The following is a description of a gene set: High-throughput gene expression profiling has become an important tool for investigating transcriptional activity in a variety of biological samples. To date, the vast majority of these experiments have focused on specific biological processes and perturbations. Here, we have generated and analyzed gene expression from a set of samples spanning a broad range of biological conditions. Specifically, we profiled gene expression from 91 human and mouse samples across a diverse array of tissues, organs, and cell lines. Because these samples predominantly come from the normal physiological state in the human and mouse, this dataset represents a preliminary, but substantial, description of the normal mammalian transcriptome. We have used this dataset to illustrate methods of mining these data, and to reveal insights into molecular and physiological gene function, mechanisms of transcriptional regulation, disease etiology, and comparative genomics. Finally, to allow the scientific community to use this resource, we have built a free and publicly accessible website (http://expression.gnf.org) that integrates data visualization and curation of current gene annotations. species: Homo sapiens Human Gene Set: SU_KIDNEY Genes up-regulated specifically in human kidney tissue. from publication Su AI, Cooke MP, Ching KA, Hakak Y, Walker JR, Wiltshire T, Orth AP, Vega RG, Sapinoso LM, Moqrich A, Patapoutian A, Hampton GM, Schultz PG, Hogenesch JB (PMID 11904358), and this is the list of marker genes: CUBN (cubilin), KL, SLC12A1, ENPEP, SLC17A1, XPNPEP2, SLC6A13, HES2, FMO1, KCNJ1, AQP2, CLCN5, HNF1B, SLC22A2 (solute carrier family 22 member 2), POU3F4